The following is a description of a gene set: Human Gene Set: HP_ABNORMAL_ACETABULUM_MORPHOLOGY studied in species Homo sapiens An abnormality of the acetabulum, i.e., the Acetabular part of hip bone, which together with the head of the femur forms the hip joint. Abnormal acetabulum morphology, and this is the list of marker genes: AP4B1, RNU4ATAC, LAMA5, CHRNG, ARSK, COL1A1, XYLT1, FGFR3, B3GALT6, TMEM67, MMP2, IFIH1, DYNLT2B, GPX4 (glutathione peroxidase 4), NANS, LRP1, BGN, GNPNAT1, GUSB, DYNC2I1, SLC35D1, HOXA11, RAB23, COMP, COL25A1, INPPL1, TGFB2, HYAL1 (NCBI Gene Id 3373), MYO18B, SERPINF1, EVC2, NRCAM, TRPV4, PTH1R, WDR19, RAB33B, ARSB, UFSP2, IFT52, COL10A1, RPS15A, PLOD1, MATN3, CCN6, CENPJ, PAM16, CRTAP, PHLDB1, CEP120, DYNC2H1, SCYL2, FGFR2, BMP4, POLR1A, AP4E1, FKBP10, CSPP1, SMARCAL1, GLB1, FLNB, TIMM22, AP3B1, TONSL, CSGALNACT1, TGFBR2, AP4M1, CTCF, HSPG2, ERCC1, TBX4, CHD4 (NCBI Gene Id 1108), EVC, SLC26A2, EIF4A3, SMAD3, TRIP11, GNPTAB, ERGIC1, COL1A2, WDR35, COG1, KIAA0586, CANT1, FIG4, EXTL3, FBN1, RINT1, DYM, SLC35A3, AP4S1, COL2A1, CCN2, LYSET, VPS33A